Given this list of marker genes Ffar1, Adcyap1r1, Bmp4, Bak1, Gimap5, Lhcgr, Gimap3, Akap5, Grin1, P2rx4, Bax, Trpc3, P2rx7, Cav1, Oga, Asph, Cd4, here is a description of the gene set: Any process that increases the rate of the directed movement of calcium ions into the cytosol of a cell. The cytosol is that part of the cytoplasm that does not contain membranous or particulate subcellular components. species: Mus musculus Mouse Gene Set: GOBP_POSITIVE_REGULATION_OF_CALCIUM_ION_TRANSPORT_INTO_CYTOSOL